Given this list of marker genes EHHADH, CROT, PEX26, TYSND1, USP9X, AGPS, ACOT4, IDH1, AGXT, PEX10, IDE, PEX2, DAO, ECH1, UBE2D1, HMGCL, ACOX2, NUDT19, PEX6, NUDT7, GSTK1, ZFAND6, LONP2, ACOX1, PEX12, CRAT, NOS2, ACAA1, SLC27A2, UBA52, HAO2, HAO1, MPV17, PECR, HACL1, PAOX, ECI2, PHYH, RPS27A, MLYCD, ACOT2, UBB, BAAT, CAT, DDO, PEX14, AMACR (NCBI Gene Id 23600), SCP2, PEX5, PIPOX, DECR2, GNPAT, ACOT8, PEX7, UBE2D3, UBE2D2, DHRS4, ACOX3 (acyl-CoA oxidase 3, pristanoyl), PEX13, PEX1, UBC, EPHX2, HSD17B4, here is a description of the gene set: Peroxisomal protein import Human Gene Set: REACTOME_PEROXISOMAL_PROTEIN_IMPORT species: Homo sapiens